The following is a description of a gene set: studied in species Mus musculus Mouse Gene Set: GOBP_FATTY_ACYL_COA_METABOLIC_PROCESS The chemical reactions and pathways involving a fatty-acyl-CoA, any derivative of coenzyme A in which the sulfhydryl group is in thiolester linkage with a fatty-acyl group., and this is the list of marker genes: Far2, Acsl6, Elovl7, Elovl5, Acat1, Them5, Acsl5, Elovl4, Nudt19, Far1, Acsl3 (acyl-CoA synthetase long-chain family member 3), Abcd1, Acot2, Hsd17b4, Dgat2, Fitm2, Nudt7, Elovl1, Acot7, Elovl3, Nudt8, Gcdh, Acsl4, Acsl1, Dgat1, Elovl6